Given this list of marker genes PITX2, CACNA1S, FOXL2, MYH15, MYOM2, MYOM1, here is a description of the gene set: species: Homo sapiens The process whose specific outcome is the progression of the extraocular skeletal muscle over time, from its formation to the mature structure. The extraocular muscle is derived from cranial mesoderm and controls eye movements. The muscle begins its development with the differentiation of the muscle cells and ends with the mature muscle. An example of this process is found in Mus musculus. Human Gene Set: GOBP_EXTRAOCULAR_SKELETAL_MUSCLE_DEVELOPMENT